Given this list of marker genes FGFRL1, RAB14, FLRT3, THBS1, FLRT2, NOG, FLRT1, CREB3L1, MIR503, FGF8, FGF20, WNT4, MIR424, FGF16, CRKL, KIF16B, MIR146A, CHURC1, FGF14, SHISA2, FGFBP3, CEP57, IQGAP1 (NCBI Gene Id 8826), FRS3 (NCBI Gene Id 10817), FGF22, EXT1, ZDHHC16, OFD1, FGF1, APLN, CTNNB1, MIR149, SOS1, FUZ, FGF23, FGFR3, FGF18, GRB2, FGF5, NDST1, FGF10, FGF19, SPRY3, TBX2, TRIM71, FGF21, FRS2, KL, FGF12, SHCBP1, FGF2, FIBP, FGF9, GPC1, FGF4, SMOC2, IFT80, FGF7, MIR1-1, MIR573, CCN2, SULF2 (NCBI Gene Id 55959), NPTN, PRKD2, GALNT3 (polypeptide N-acetylgalactosaminyltransferase 3), FGFR4, LRIT3, NGFR, KLB, SULF1, GATA3, SPRY2, FGFR1, SPRY1, FGF17, FGF6, NRXN1, FGFBP1, WNT5A, MIR16-1, ITGB1, PRDM14, FGF3, SPRY4, RHOD, HHIP, PTPN11, FAM20C, SHOC2, OTX2, DSTYK, RUNX2 (NCBI Gene Id 860), FGFR2, here is a description of the gene set: studied in species Homo sapiens Human Gene Set: GOBP_FIBROBLAST_GROWTH_FACTOR_RECEPTOR_SIGNALING_PATHWAY The series of molecular signals generated as a consequence of a fibroblast growth factor receptor binding to one of its physiological ligands.